Given this list of marker genes CSF1, DCSTAMP, FER, DOK1, PTPN2, TREM2, PDE2A, CSF1R, MST1R, PDE1B, TLR4, TLR2, STAP1, here is a description of the gene set: studied in species Homo sapiens Human Gene Set: GOBP_CELLULAR_RESPONSE_TO_MACROPHAGE_COLONY_STIMULATING_FACTOR_STIMULUS Any process that results in a change in state or activity of a cell (in terms of movement, secretion, enzyme production, gene expression, etc.) as a result of a macrophage colony-stimulating factor stimulus.